Given this list of marker genes CSF1, PDIK1L, PCDHA11, MED7, TBR1, SLC25A15, PCDHA1, CBFB, PCDHAC2, CADM2 (NCBI Gene Id 253559), SEC16B, LRP8, SIGLEC5, TOB1, FTO, QKI, DACH1, BMPR2 (NCBI Gene Id 659), PAIP2, LUZP2, TRAPPC13, MS4A1, MECP2, TMEM182, VNN2, NALF1 (NALCN channel auxiliary factor 1), PCDHA9, LEMD3, PCDHAC1, PCDHA7, PLAAT1, CD40, GLCCI1, CCL20, PRPF4, DEK, SYPL1, PCDHA12, CNTN5, XKR4, RNF130, ATAD1, CREM, AZIN1, EGFL6, NRP1, CCL18, FGF12, CAPZA2, PCDHA4, VDAC3, PCDHA2, PCDHA5, MIER1, UBE2K, SLC24A1, HK2, MEGF10, PCDHB7, RSF1, PCDHA6, PCDHA13, CSRNP1, PCDHA10, RFFL (ring finger and FYVE like domain containing E3 ubiquitin protein ligase), PCDHA8, MTMR12, PCDHA3, GH1, RBPMS2, LINGO2, TSHZ3, here is a description of the gene set: Genes predicted to be targets of miRBase v22 microRNA hsa-miR-1322 in miRDB v6.0 with MirTarget v4 prediction scores > 80 (high confidence targets). from publication Chen Y, Wang X (PMID 31504780) Human Gene Set: MIR1322 studied in species Homo sapiens